Given this list of marker genes GUCY1B2, GUCY1A2, GSK3B (glycogen synthase kinase 3 beta), PDE4A, PDE5A, ZNF746, NOS2 (nitric oxide synthase 2), GAPDH, NOS1, GUCY1B1, PRKN, NRF1 (nuclear respiratory factor 1), TFAM, AKT3, PPARGC1A, GUCY1A1 (guanylate cyclase 1 soluble subunit alpha 1), PDE4D, NOS3, PRKG1, AKT1, PDE4B, PDE4C, AKT2, here is a description of the gene set: Human Gene Set: WP_SILDENAFIL_TREATMENT species: Homo sapiens Sildenafil treatment